The following is a description of a gene set: The lipid bilayer surrounding a vesicle transporting substances between the trans-Golgi network and other parts of the cell. species: Homo sapiens Human Gene Set: GOCC_TRANS_GOLGI_NETWORK_TRANSPORT_VESICLE_MEMBRANE, and this is the list of marker genes: AP1M2, AP1G2, AFTPH, NRGN, SLC18A3, RASSF9, AP1S1, NCALD, CLTB, AP1G1, AP1S3, CLTCL1, AP1B1, AP1S2, CLTA, CLTC, SYNRG, AP4B1, AP2A1, AP1M1 (NCBI Gene Id 8907), CLBA1 (NCBI Gene Id 122616)